The following is a description of a gene set: Here we show the antimyeloma cytotoxicity of adaphostin and carried out expression profiling of adaphostin-treated multiple myeloma (MM) cells to identify its molecular targets. Surprisingly, c-Jun was the most up-regulated gene even at the earliest point of analysis (2 h). We also observed adaphostin-induced c-Abl cleavage in immunoblot analysis. Proteasome inhibitor bortezomib, but not melphalan or dexamethasone, induced similar effects, indicating unique agent-dependent mechanisms. Using caspase inhibitors, as well as caspase-resistant mutants of c-Abl (TM-c-Abl and D565A-Abl), we then showed that c-Abl cleavage in MM cells requires caspase activity. Importantly, both overexpression of the c-Abl fragment or c-Jun and knockdown of c-Abl and c-Jun expression by small interfering RNA confirmed that adaphostin-induced c-Jun up-regulation triggers downstream caspase-mediated c-Abl cleavage, inhibition of MM cell growth, and induction of apoptosis. Finally, our data suggest that this mechanism may not only be restricted to MM but may also be important in a broad range of malignancies including erythroleukemia and solid tumors. Down-regulated genes in MM1.S cells (multiple myeloma) treated with adaphostin, a tyrosine kinase inhibitor with anticancer properties. studied in species Homo sapiens Human Gene Set: PODAR_RESPONSE_TO_ADAPHOSTIN_DN from publication Podar K, Raab MS, Tonon G, Sattler M, Barilà D, Zhang J, Tai YT, Yasui H, Raje N, DePinho RA, Hideshima T, Chauhan D, Anderson KC (PMID 17308109), and this is the list of marker genes: CCNE1, CCNF, ACTG1 (actin gamma 1), UNG, SDC1, INSIG1, CXCL10, CX3CR1, RRP1B, TFRC, INAVA, DHCR7, MSMO1, SCD, HK2, IDI1, GLI2, FDFT1